Given this list of marker genes CEBPD, PDHX, PDS5B, MICB, COPS6, CDC123, ADA2, GLT8D1, MAN1A2, SURF1, ADA, THOP1, ABCB9, NCOA4, AVEN, TRABD, CHST15, POLR2K, SS18, SCO2, RAD51AP1, LIME1, ACSL4, IBTK, MAP2K6, CADM1 (cell adhesion molecule 1), CREB3L2, TOP1, HCCS, CERK, SPATS2, DPP3, SLC39A7, RNF34, NDC1, CLPTM1, GSPT1, MRPS18B, CCT5, SEC24A, GOLPH3L, STX11, PGRMC2 (NCBI Gene Id 10424), LEPROTL1 (NCBI Gene Id 23484), UFM1, UBXN4, TIMM17A, IFT52, NAA10, COPS8, H2BC7, SSR3 (NCBI Gene Id 6747), COA3, RRBP1, ALDH18A1 (aldehyde dehydrogenase 18 family member A1), GALNT2, RCHY1, CCDC88C, FBXO5, RARS1, MRPL20, PRCP, TIMP2, ETNK1 (ethanolamine kinase 1), CSNK2A1, MAIP1, DECR1, SERINC3, CDK5, UBE2M, TFB2M, MSH6, NHERF1, SKIC8, PPIP5K2, ICAM4, RPAP3 (NCBI Gene Id 79657), VCP, GFPT1 (NCBI Gene Id 2673), RINT1, CARS1, TFPT (NCBI Gene Id 29844), RGS16, FUT8, RGS10, C11orf24, AGGF1, SERF2, FAF2, TM9SF3, FNDC3B, GET1, ATP5IF1, RHOQ (ras homolog family member Q), ACBD3, CIAO1, ZBTB48, HDAC2, AACS, TBC1D1, ACTR1A, CLIC4, SNRPB2, NEK4, RUVBL1, UCK2 (uridine-cytidine kinase 2), MRPS15, POLR3E, H1-2 (NCBI Gene Id 3006), YIPF2 (NCBI Gene Id 78992), GNS, CTSC, EMC9, MXD4, UBE3A (ubiquitin protein ligase E3A), TAPBPL, BAK1, CALM3, SNAPC5, AGA, GPN2, TMEM165, MPC2, EPRS1, GOLGA5, SAE1, SLC33A1, AIMP2, DNM1L, MLEC, C5orf22, R3HDM1, CCPG1, PIGK, C21orf91 (chromosome 21 open reading frame 91), ATP5F1D, NDUFAF1, UGDH, HMBS, LAP3, INPP1, TCF3, DSTN, ARSA, NDFIP1, EDC4, HAT1, TOP6BL (NCBI Gene Id 79703), CTBS, PSMC4, BHLHE41, TRAPPC2L, STIP1 (NCBI Gene Id 10963), EIF1AY (NCBI Gene Id 9086), NRBP1, ISOC1, EIF2B3, TST, ITFG1, SGK1, PDXDC1, GPAA1, UBFD1, ABHD14A, GMPPB, YIPF3, AASDHPPT, SRPRA, UFSP2, RRM1, PDCD5, TXN2, PCCB, PSMD11, MIA3, TMX2, ALG9, SSR2, KPNA3, NDUFAF3, APOBEC3G, WFS1, WDR45, FNDC3A, ALG3, MFF (mitochondrial fission factor), CLPB, DDB1, ST6GALNAC4, TM9SF4, RUSF1, KCNA3, IL6ST, GADD45A, RCN1, ZBP1, SLC25A4, YWHAE, CETN3, IFI35, here is a description of the gene set: species: Homo sapiens Human Gene Set: GSE22886_IGM_MEMORY_BCELL_VS_BLOOD_PLASMA_CELL_DN from publication Abbas AR, Baldwin D, Ma Y, Ouyang W, Gurney A, Martin F, Fong S, van Lookeren Campagne M, Godowski P, Williams PM, Chan AC, Clark HF (PMID 15789058) Genes down-regulated in comparison of memory IgM B cells versus blood plasma cells. Immune cell-specific expression is one indication of the importance of a gene's role in the immune response. In order to identify such patterns, we set out to broadly profile gene expression in a variety of immune cells.